Given this list of marker genes MALT1, BIRC3, BCL10, NOD2, FOXP1, here is a description of the gene set: Human Gene Set: HP_POSTERIOR_UVEITIS Posterior uveitis species: Homo sapiens Inflammation of the uveal tract in which the primary site of inflammation is the retina or choroid.